Given this list of marker genes Slc22a5, Slc1a4, Slc18a2, Slc12a3, Slc4a8, Slc12a2, Slc16a7, Slc13a5, Slc17a5, Slc38a7, Slc45a2, Slc1a6, Slc34a3, Slc17a7, Slc6a7, Slc5a7, Slc6a17, Slc38a2, Slc16a5, Slc24a1, Slc39a10, Slc28a2b, Slc4a4, Slc10a1, Slc20a2, Slc1a1, Mfsd12 (major facilitator superfamily domain containing 12), Slc28a2, Slc1a7, Slc10a3, Slc10a4-ps, Slc4a11, Mfsd4b1, Slc36a4, Slc17a6, Slc38a3, Slc15a3, Slc15a4, Slc39a12, Slc10a6, Slc46a1, Slc13a2, Slc5a6, Slc4a9 (solute carrier family 4, sodium bicarbonate cotransporter, member 9), Slc24a3, Slc15a2, Slc12a5, Slc17a8 (solute carrier family 17 (sodium-dependent inorganic phosphate cotransporter), member 8), Slc16a14, Slc10a2, Slc36a1, Slc4a5, Slc6a8, Slc6a4, Slc5a5, Slc10a5, Slc24a5, Slc16a13, Slc45a3, Slc5a11, Slc17a2 (NCBI Gene Id 218103), Slc2a4, Slc1a2, Slc39a5, Slc4a7, Slc34a2, Slc12a9, Slc5a3, Slc38a4, Slc5a2, Slc6a18, Slc23a1, Slc39a4, Slc38a1, Slc36a2, Slc45a4, Slc39a6, Slc6a20b, Slc6a19, Slc13a1, Slc6a13, Slc17a4, Slc5a1, Slc29a1, Slc5a9, Slc36a3, Slc22a18, Slc6a9, Slc22a4, Slc1a5, Slc34a1 (solute carrier family 34 (sodium phosphate), member 1), Slc6a2 (NCBI Gene Id 20538), Slc2a13, Slc45a1, Slc6a15, Slc4a10, Slc6a6, Slc5a4b, Slc12a1, Slc6a5, Slc6a12, Slc17a1, Slc10a7, Ctns, Slc6a1, Slc28a1, Slc15a1, Slc12a8, Slc13a4, Slc18a1, Slc39a8, Slc25a22, Slc12a7, Mfsd2a, Slc28a3, Slc23a2, Slc39a14, Slc5a10, Slc6a11, Slc5a12, Slc16a8, Slc16a1, Slc16a4, Slc24a2, Slc15a5, Slc16a3, Slc24a4, Slc10a4, Slc1a3, Slc13a3, Gm5134, Slc25a18, Mfsd2b, Slc46a3, Slc20a1, Slc22a1, Slc11a2, Slc22a3, Slc6a3, Slc6a14, Slc6a20a, Slc5a8 (solute carrier family 5 (iodide transporter), member 8), Slc25a3, Slc12a6, Slc12a4, Slc5a4a, Slc16a11, here is a description of the gene set: Enables the active transport of a solute across a membrane by a mechanism whereby two or more species are transported together in the same direction in a tightly coupled process not directly linked to a form of energy other than chemiosmotic energy. Mouse Gene Set: GOMF_SYMPORTER_ACTIVITY species: Mus musculus